The following is a description of a gene set: species: Homo sapiens Sperm cells with abnormally short flagella. Human Gene Set: HP_SHORT_SPERM_FLAGELLA Short sperm flagella, and this is the list of marker genes: CFAP58, DNAH7, CFAP61, BRWD1, CFAP65, DNAH8, TTC29, DNAH2 (NCBI Gene Id 57637), IFT74, FSIP2, CFAP251, CFAP47, TTC21A, CCDC146, DNAH10, WDR19, STK33, DZIP1, SSX1, LRRC23, DNHD1, DNAH1, AKAP3, DNAH17 (NCBI Gene Id 8632), AK7, CCDC34, CFAP70, CATIP (NCBI Gene Id 375307), CFAP43, CFAP74, QRICH2, CFAP91, DRC1, USP26, CFAP69, CFAP44